The following is a description of a gene set: studied in species Homo sapiens The effect of human cytomegalovirus (HCMV) infection on cellular mRNA accumulation was analyzed by gene chip technology. During a 48-h time course after infection of human diploid fibroblasts, 1,425 cellular mRNAs were found to be up-regulated or down-regulated by threefold or greater in at least two consecutive time points. Several classes of genes were prominently affected, including interferon response genes, cell cycle regulators, apoptosis regulators, inflammatory pathway genes, and immune regulators. The number of mRNAs that were up-regulated or down-regulated were roughly equal over the complete time course. However, for the first 8 h after infection, the number of up-regulated mRNAs was significantly less than the number of down-regulated mRNAs. By analyzing the mRNA expression profile of cells infected in the presence of cycloheximide, it was found that a minimum of 25 mRNAs were modulated by HCMV in the absence of protein synthesis. These included mRNAs encoded by a small number of interferon-responsive genes, as well as beta interferon itself. Cellular mRNA levels in cytomegalovirus-infected cells were compared to the levels in cells infected with UV-inactivated virus. The inactivated virus caused the up-regulation of a much greater number of mRNAs, many of which encoded proteins with antiviral roles, such as interferon-responsive genes and proinflammatory cytokines. These data argue that one or more newly synthesized viral gene products block the induction of antiviral pathways that are triggered by HCMV binding and entry. Human Gene Set: BROWNE_HCMV_INFECTION_30MIN_DN from publication Browne EP, Wing B, Coleman D, Shenk T (PMID 11711622) Genes down-regulated in primary fibroblast cell culture at 30 min time point after infection with HCMV (AD169 strain)., and this is the list of marker genes: TGM3, POLR2D, GLOD4, MALL, DST, CUBN, FAM169A, SSX5, ZNF124, IPO8, KALRN, PVALB, LINC00869, AXL, CXCL6, XCL2, OLIG2, AURKA, BCAS1, PRKAR2B, ORC4, GLMN, RUBCN, TNFSF11, BTN3A2 (butyrophilin subfamily 3 member A2), NTSR1, ITSN2, DUSP2, PTPN21, NOVA1, VDAC1P3, TMEM186, ABCA4, OPHN1, RO60, PTP4A1, ZNF205, CBFA2T3, CDH13, GALK2, KNOP1, MUC4, RUFY3, RIPOR2, LAPTM5, GRIA3, CEL, MAGEA2, KCNF1, THPO, DMXL1, P2RY10, ACTN2, EPB42, MIR3648-1, CYP4F2, LRP8, RGS3, CDK1, KIFC1, COLEC10, MIOS, SLC25A12, JPT2, CDC40, RPSA, CASP6, PRKAB2, HOXD3, VAV1, TRAF3IP3 (TRAF3 interacting protein 3), ZSCAN12, RAG2, SZRD1, LRRC17, SLC6A15, SHC2, GRM5, OPRK1, GLB1L2, LMO7, CENPE (centromere protein E), DHFR, SIRPA, DSP, ZNF142, GZMK, KLRK1 (killer cell lectin like receptor K1), CHL1, ITGB2, GPSM3, IL9R, PRSS3P3, DLGAP1 (NCBI Gene Id 9229), ATG5, MOGS, GJA4, GNRH1, IFNG, SLC12A1, VWA5A, RER1, MAPKAPK5 (MAPK activated protein kinase 5), MMP3, GSAP (gamma-secretase activating protein), GJA1, RABGAP1L, BRCA2, ITPKA, TAF13, TJP1, PTH, RHCE, RFX1, SOCS1, NLRP1, ALMS1, DDX17, MUSK, NR1H3, OTC, DUSP4, EEF1A1, VAPB, ZNF749, NCAPH, RALGPS1, HMBS, SAA4, SUCO, GSTT4, EEA1, PPFIA2, RSRP1, RANBP6, SSTR4 (NCBI Gene Id 6754), CSH1, DENND2B, USPL1, PAEP, POLR1F, NFYA, RCC1, TNFRSF1B, CDC42